The following is a description of a gene set: species: Mus musculus Mouse Gene Set: GOMF_XYLOSYLTRANSFERASE_ACTIVITY Catalysis of the transfer of a xylosyl group to an acceptor molecule, typically another carbohydrate or a lipid., and this is the list of marker genes: Rxylt1, Xylt2, Large1, Poglut1, Large2, Gxylt1, Poglut2, Poglut3, Xylt1, Gxylt2, Xxylt1